Given this list of marker genes ST3GAL2, NEU3, B4GALNT1, ST3GAL1, ST3GAL4, B3GALT4, HEXB, NEU4, ST8SIA6, HEXA, ST8SIA5, ST8SIA1, ST3GAL5, here is a description of the gene set: Ganglio series sphingolipid metabolism studied in species Homo sapiens Human Gene Set: WP_GANGLIO_SERIES_SPHINGOLIPID_METABOLISM